Given this list of marker genes MIR130A, FKBP1A, MIR26A1, ING1, MIR372, ZBTB7A, ENG, NCLN, MIR100, INTS9, HTRA3, STRAP, LRP1, HIPK2, MIR497, MIR142, PPARA, ZNF451, WNT1, MICOS10-NBL1, UBE2D1, MIR199A1, GREM1, FAM89B, LTBP1, TMPRSS6, MIR376C, SPRED2, MIRLET7B, OVOL2, BCL9L, FSTL3, GDF3, SPRED3, ONECUT2, MIR101-1, ERFE, HSPA1A, CAV1, MIR210, TMEM53, ACVR1, MIR19A, MIR564, LRP2, ARID4A (NCBI Gene Id 5926), SOST, NOG, TP53 (NCBI Gene Id 7157), MIR302B, MIR26B, SFRP2 (NCBI Gene Id 6423), STUB1, HSPA5, MIR146A, WNT5A, MIR98, HTRA4, SNX6, ARID4B, NBL1, RBBP4, SIN3A, FBN2, VWC2, SIRT1, BMPER, MIR490, MIR373, MIR27B, HDAC2, HTRA1, TBX20, MECOM, PBLD, MIR18A, EMILIN1, UCMA, MIR199B, CER1, TOB1, CHST11, WFIKKN2, SOSTDC1, ADAMTSL2, SMAD6, SMURF2, DAND5, LEMD3, OGT, MIR424, ABL1, MIR181A2, MIR125B1, CRIM1, FST, MIR885, FBN1, MIR19B1, DKK3, FKBP1C, CHRDL1, SLC2A10, SKOR2, CILP, MIR23A, MIRLET7G, DACT2, GLG1, CAV2, MIR498, RASL11B, MIR204, SMAD7, MIR140 (NCBI Gene Id 406932), MIR145, GREM2, PPARG, NOMO1, VASN, PMEPA1, TWSG1, SAP130 (Sin3A associated protein 130), MIR29B1, PEG10, MIR342, NKX2-1, MIR27A, MIR205, NRROS, ASPN, SNX25, PPM1A, BMP2, FZD1, LRRC32, WFIKKN1, HJV, MIR302C, VEPH1, GPR155, MIR195, XBP1, MIR9-1, SORL1, SMURF1, MTMR4, PRDM16, LDLRAD4, CTDSPL2, PIN1, PDPK1 (3-phosphoinositide dependent protein kinase 1), CHRDL2, RBBP7, SPRED1, MIR323A, BRMS1, TRIM33, CRKL, CDH3, MIR106A, SKIL, NOMO3, SKOR1, ING2 (inhibitor of growth family member 2), MIR361, USP15, BAMBI, EID2, IL17RD, TGFBR3 (transforming growth factor beta receptor 3), MIR17, GDF15, SAP30, CIDEA (NCBI Gene Id 1149), CHRD, MAGI2, SKI, BRMS1L, MIR93, ADAM17, SAP30L, SUDS3, MIR520C, TNFAIP6, DKK1, SINHCAF, ONECUT1, RBPMS2, SFRP1, MIR483, TET1, CD109, SPART, MIR15B, MIRLET7A1, DLX1 (distal-less homeobox 1), IGSF1, UBE2D3, MIR20A, HDAC1, VWC2L, CCN3, SPRY1, SPRY2, MIRLET7F1 (NCBI Gene Id 406888), NOTCH1, MIR214, here is a description of the gene set: Any process that decreases the rate, frequency, or extent of the series of molecular signals generated as a consequence of a transmembrane receptor serine/threonine kinase binding to its physiological ligand. studied in species Homo sapiens Human Gene Set: GOBP_NEGATIVE_REGULATION_OF_TRANSMEMBRANE_RECEPTOR_PROTEIN_SERINE_THREONINE_KINASE_SIGNALING_PATHWAY